Given this list of marker genes CDS2, RPS6KA1, INSC, SASH3 (NCBI Gene Id 93952), MEA1, ZBED3, WASHC5, CRKL, ERLIN1, UQCRHL, CCSAP, PRKAB1, HPS3, RPP25L, ALKBH4, SMUG1, SYS1, PNN, BMS1, C8orf58, NUDT16L1, PIMREG, LRRC75A, RNF181, ATPAF1, MED17, CCDC134, NHLRC3, UBA2, NELFA, CREBZF, ORMDL3, RPUSD4, METTL9, ZNF770, ZBTB1, CHST14, OSGIN1, ARRDC3, MFSD12, SLC30A5 (NCBI Gene Id 79021), C8G, STAT2, MRPS2, S1PR2, POLR3K, HHEX, ASB8, GNB1, MED22, SH3BP2, SS18L2, MTCP1 (mature T cell proliferation 1), CEP19, CYTH4, ZDHHC9, CCDC117, PEX12, ZNF346, ZNF280B, CD300LB, MFAP3, ZNF687, KBTBD4, SUSD3, YBX1, MSRB2, SURF6, ENSG00000267882, MBLAC2, GAN, RMND5B, SNX5, TMEM18, TRIM65, RIT1, ANKLE1, MOAP1, CASP2, AURKB, TCTA, SLC30A1, SNX8, VPS33A, LCMT2, CLEC1A, ZNF623, HJURP, CBX5, NPC1, CNR2, NAGLU, TMEM140, COA5, PWWP2A, C16orf54, HMGCL (3-hydroxy-3-methylglutaryl-CoA lyase), SERAC1, BET1L, THBD, EXOC8, TMEM80, ANAPC2, MTIF3 (mitochondrial translational initiation factor 3), ZFP90, FGFR1OP2, AP3M2, CASS4, EPM2AIP1, ZNF322, ORAI3, LRATD2, OSTM1, KCTD21, ACOT2, MASTL, VPS26A, BID, MBP, CCDC115, ZNF627, DCAF7, LIPT1, PDP1, PDIK1L, PMM1, LTO1, TSPAN14, CBX6, ACOT13, TUBGCP4, STOML1, ATG12, SKA2, DDIT3, UBR7, ATG16L1, APOBEC1, RNFT2, MRPL43, AIMP1, BORA, FBXL12, FAM78A, CDK20, ARMC7, RSL24D1, ZNF319, ARHGAP25 (NCBI Gene Id 9938), SLC25A30, TOR4A (NCBI Gene Id 54863), ZNF217, ZBTB34, ZBTB45, AAGAB, ORMDL1, TMX2, ZNF707, MCFD2, KAT14, ABCG1, VHL, ARRDC2, SNX32, ACVR1B, IRAK1BP1, LHFPL2, OGFRL1, RIOX1, MFSD4B, H2AJ, RNF187, ZNF597, TRIM59, PITHD1, AKTIP, POLR2I, DYNC1LI2, KHDC4, EMC3, SCARNA13 (NCBI Gene Id 677768), NANP, ARL14EP, NATD1, TAF8, PHF23, IER5L, ZRANB2, ANKRD49 (NCBI Gene Id 54851), BTBD1, BLOC1S2, ZNF526, PPP1R3B, MAD2L1BP, RAB40C, PLEKHM2, RAB11FIP5, TXNIP, ZNF503, MGME1, here is a description of the gene set: The innate immune system is a two-edged sword; it is absolutely required for host defense against infection, but if left uncontrolled can trigger a plethora of inflammatory diseases. Here we used systems biology approaches to predict and validate a gene regulatory network involving a dynamic interplay between the transcription factors NF-κB, C/EBPδ, and ATF3 that controls inflammatory responses. We mathematically modeled transcriptional regulation of Il6 and Cebpd genes and experimentally validated the prediction that the combination of an initiator (NF-κB), an amplifier (C/EBPδ) and an attenuator (ATF3) forms a regulatory circuit that discriminates between transient and persistent Toll-like receptor 4-induced signals. Our results suggest a mechanism that enables the innate immune system to detect the duration of infection and to respond appropriately. species: Homo sapiens Genes up-regulated in comparison of unstimulated macrophage cells versus macrophage cells stimulated with LPS (TLR4 agonist) for 80 min. from publication Litvak V, Ramsey SA, Rust AG, Zak DE, Kennedy KA, Lampano AE, Nykter M, Shmulevich I, Aderem A (PMID 19270711) Human Gene Set: GSE14769_UNSTIM_VS_80MIN_LPS_BMDM_UP